The following is a description of a gene set: species: Homo sapiens Dendritic cells (DCs) and macrophages (MPs) are important for immunological homeostasis in the colon. We found that F4/80hi CX3CR1hi (CD11b+CD103-) cells account for 80% of mouse colonic lamina propria (cLP) MHC-IIhi cells. Both CD11c+ and CD11c- cells within this population were identified as MPs based on multiple criteria, including a MP transcriptome revealed by microarray analysis. These MPs constitutively released high levels of IL-10 at least partially in response to the microbiota via an MyD88-independent mechanism. In contrast, cells expressing low to intermediate levels of F4/80 and CX3CR1 were identified as DCs, based on phenotypic and functional analysis and comprise three separate CD11chi cell populations: CD103+CX3CR1-CD11b- DCs, CD103+CX3CR1-CD11b+ DCs and CD103-CX3CR1intCD11b+ DCs. In non-inflammatory conditions, Ly6Chi monocytes differentiated primarily into CD11c+, but not CD11c- MPs. In contrast, during colitis, Ly6Chi monocytes massively invaded the colon and differentiated into pro-inflammatory CD103-CX3CR1intCD11b+ DCs, which produced high levels of IL-12, IL-23, iNOS and TNF. These findings demonstrate the dual capacity of Ly6Chi blood monocytes to differentiate into either regulatory MPs or inflammatory DCs in the colon, and that the balance of these immunologically antagonistic cell types is dictated by microenvironmental conditions. Human Gene Set: GSE27859_MACROPHAGE_VS_CD11C_INT_F480_INT_DC_UP from publication Rivollier A, He J, Kole A, Valatas V, Kelsall BL (PMID 22231304) Genes up-regulated in macrophages versus dendritic cells sorted as ITGAX int and EMR1 int., and this is the list of marker genes: CAMTA2, CEACAM18, UACA, H1-10, BLOC1S3, ATOX1, SSR3, KCNK13, POU2F3, JAK2, B3GNT5, PPBP, RAB30, TPBG, CMTM6, SYNGR1, TMTC2, MVP, SDF2L1, CAMSAP2, ADAM15, PSME1, IL12A, HDC, CSF2RBP1, SCIN (NCBI Gene Id 85477), PROKR1, HCST, EFR3A, CCR4, TANC1, LRRC8A (leucine rich repeat containing 8 VRAC subunit A), VCAN, IFITM1, KREMEN1, ITGB1, ACSL4, CD52, PALLD (palladin, cytoskeletal associated protein), DCP1A, PLA1A, MDH2, CLINT1, CASD1, TMEM176B, IQSEC2, TCF3, BLNK, ANTXR1, EME2, RCL1, MAP2K6, ATP1A3, HIPK3, PARL, BMP2K, ITCH (NCBI Gene Id 83737), NCF4, ZFHX3, PTAFR, DLL4 (delta like canonical Notch ligand 4), EML4, LIPE, TXNIP, MOB1A, TMEM50B (transmembrane protein 50B), NFATC2, GABRA6, IKBKB, RNF115, DNLZ, HS1BP3 (NCBI Gene Id 64342), FLNB, RNF111 (NCBI Gene Id 54778), GRAMD2B, PDGFRB, ANKRD27, NOTUM, MIR155 (NCBI Gene Id 406947), TES, TAL1, CDK20, NAA60, MPZL1, VDAC1, ACP3, RAPGEF2, ALPK1, IRF5 (NCBI Gene Id 84729), MAG, CSF1, TNFRSF9, GJA5 (NCBI Gene Id 2702), AGTRAP, EIPR1, PPP1R12A, CYB561D1, OTUD5, DHRS1, HEMK1, CRTC1, OPRK1, RNF144A, CD86, CD14, BRAP, PRRG1, MACROH2A2 (macroH2A.2 histone), KICS2, LHFPL6, GATA2, TWSG1, PIK3R3, STAG1, CST7, RABEP2, SMOX, CDKN2AIPNL, ECT2L, STX11, CCDC116, FBXO46, HS3ST3B1, CLIC4, SLAMF8, IGF1R, TMEM168, USP4, GALNT2, RBPJ, SS18, RGS12, TRAF2, ANPEP, AK4, IL10RA, TLN2, KSR1, PLEKHG2, ETV6, OTOP1, BPTF, SEC23B, ANTXR2, SPECC1, LEMD2, DAP, KCNG2, HS3ST3A1, MIR539, PPP1R13B, SLAMF1, VWDE (von Willebrand factor D and EGF domains), NDUFA1, STAT4, PPP3R2, SCNN1G, CPNE2, PROCR, IRF8, PPP4R2 (NCBI Gene Id 56340), SEC11A, PLXDC2, SLC12A4, GPR18, MED13, DCLRE1B, FOXP4, SENP1, CASP7, LTB4R